Given this list of marker genes Sdhaf4, Hnrnpa2b1, Chic1, Ube2t, Slc30a9, Rnf115, Wdr37, Npbwr1, Dlgap1, AI597479, Cnrip1, Pdgfra, Ric3 (RIC3 acetylcholine receptor chaperone), Txndc9, Prom1, Tusc1, Plag1, Nek1, Hikeshi, Rab3b, Nufip2 (nuclear FMR1 interacting protein 2), Hcn1, Ankra2, Ift88, Map3k5, Elovl5, Fign, Pim3, Khdrbs1, Zfp493, Pom121, Pramel29, Psmd9, Kras, Vdac3, Gipc2, Mitf, Id4, Pign, Zfp738, Gpr107, Fat1, Lrrc58, Dcun1d4, Tmem127, Ddx4, Aak1, Chuk, Yy1, Cipc, Nhlrc3, Rbmx, Cip2a, Ppp1cb, Cthrc1, Prr23a3, Ankrd28, Ddx52, Osbpl1a, P2rx3, Ccp110, Zfp459, Dlat, Scd3, Esf1, Usp6nl, Prkci, Kcnh5, Onecut2, Spdl1, Atp11a, Ctbp2, Dis3l2, Sema3c, Ube2d1 (ubiquitin-conjugating enzyme E2D 1), Pes1, Tra2a, Ctnnd1, Fbn1, Slain2, Pabir1, Trub2, Kif2a, Bivm (NCBI Gene Id 98474), Zfp874a, Pcdh18, Rsbn1l (round spermatid basic protein 1-like), Klhl13, Adamts8, Denr, Pafah1b1, Rfx4, Mbtps2, Zfp759, Tcte1, Akr1c20 (aldo-keto reductase family 1, member C20), Ubr3, Stx16, Zfp326 (NCBI Gene Id 80580), Tmem255a, Ppp6r3, Tead1, Itga6, Zfp975, Peg10, here is a description of the gene set: species: Mus musculus Mouse Gene Set: MIR_7013_3P from publication Chen Y, Wang X (PMID 31504780) Genes predicted to be targets of miRBase v22 microRNA mmu_miR_7013_3p in miRDB v6.0 with MirTarget v4 prediction scores > 80 (high confidence targets).